The following is a description of a gene set: A protein complex which is capable of GABA receptor activity. Upon binding of gamma-aminobutyric acid (GABA) it transmits the signal from one side of the membrane to the other to initiate a change in cell activity. Major inhibitory receptor in vertebrate brain. Also found in other vertebrate tissues, invertebrates and possibly in plants. Effective benzodiazepine receptor. species: Mus musculus Mouse Gene Set: GOCC_GABA_RECEPTOR_COMPLEX, and this is the list of marker genes: Gabbr2 (NCBI Gene Id 279273), Gabra3, Gabrg3, Gabrp, Gabrg2, Gabrr3, Gabrb1, Gabra4, Gabra6, Gabrb3, Gabra1, Gabrr2, Gabrb2, Gabra2, Gabrr1, Gabbr1, Gabrq, Gabrg1, Gabra5, Gabre, Gabrd